The following is a description of a gene set: The presence of excessive redundant myelin in the peripheral nerve sheath. Myelin outfoldings studied in species Homo sapiens Human Gene Set: HP_MYELIN_OUTFOLDINGS, and this is the list of marker genes: MPZ, MTMR2, NEFL, SOX10, SBF1, PMP22, SBF2